Given this list of marker genes Myocd, Tbx2, Isl1, Prickle1, Rbpj, Grem1, Itgb1, T, Notch1, Srf, Nrg1, Rest, here is a description of the gene set: Mouse Gene Set: GOBP_CARDIAC_MUSCLE_CELL_MYOBLAST_DIFFERENTIATION The process in which a relatively unspecialized cell acquires specialized features of a cardiac myoblast. A cardiac myoblast is a precursor cell that has been committed to a cardiac muscle cell fate but retains the ability to divide and proliferate throughout life. studied in species Mus musculus